The following is a description of a gene set: Human Gene Set: GAUTAM_EYE_IRIS_CILIARY_BODY_ACTIVATED_T_CELLS from publication Gautam P, Hamashima K, Chen Y, Zeng Y, Makovoz B, Parikh BH, Lee HY, Lau KA, Su X, Wong RCB, Chan WK, Li H, Blenkinsop TA, Loh YH (PMID 34584087) studied in species Homo sapiens Occular cell types curated from Gautam and Hamashima et al. Multi-species single-cell transcriptomic analysis of ocular compartment regulons, and this is the list of marker genes: H1-4, ZNF778-DT, FLI1, DDB2, SRRT, TENT5C, ANKRD49, FGD3, TRAT1, AOAH, SNRNP200, SNRPD2, RBL2, NAP1L4 (nucleosome assembly protein 1 like 4), SYTL2, PRPF38B, ARID5A, TERF2IP, SLAMF6, PATL2, SNAP47, SYTL1, CCDC85B, UGP2, ABHD3, CYBC1, SH2D3A, CHST12, CDC14A, LINC00426, RPL10A, ZFAS1, PRKCB, ROCK1, ITGB2-AS1, GOLGA8A, RPL9, IL23A, RPS5 (NCBI Gene Id 6193), RPS10, CMPK1, RPL12 (ribosomal protein L12), CLIC1, SAP30, RPS6KA3 (ribosomal protein S6 kinase A3), METTL26, TNFRSF1B, ODF2L, ZFYVE28, RIPOR2, ADAM8, IQGAP1, FBXW5, IL18RAP, PDE4D, P2RY10, VSIR, OFD1, SPN, CD70, ATP5MG, ADAM19, CARD11, HERPUD2, CAPN12, CFL1, RNF213, DHRS1, RACK1, ATP2B1-AS1 (ATP2B1 antisense RNA 1), TCF7, DGLUCY, MBNL1, BTN3A1, COX4I1, ANKRD12, TRADD, LRRFIP1, SPON2, RPL17, IPCEF1, MGAT4A, WHAMM, RPS23, OCIAD2, PRMT9, SH3KBP1, EIF3M, PSMD13, DGKZ, H2AC6, MAF, NUP210, UBB, SLAMF1, NIPAL3, UBALD2, GOLGA8B, CDC42EP3, FLT3LG, H2BC8, RASA2, ST3GAL1, SYNRG, KLRC4, MYH9 (NCBI Gene Id 65212), CYFIP2, ATF7IP, GLRX (glutaredoxin), RPL35, JPT1, RGS19, MCUB, ZFAND2A, H2BC18, IL2RB, HYPK, LPIN2 (lipin 2), ATXN1, SUN2, SFI1, CAP1, TMEM71, C9orf78, TNFSF14, RORA, S1PR4 (sphingosine-1-phosphate receptor 4), EZR